The following is a description of a gene set: species: Homo sapiens part of: Lagging Strand Synthesis Reactome Pathway: Processive synthesis on the lagging strand The key event that allows the processive synthesis on the lagging strand, is polymerase switching from pol alpha to pol delta, as on the leading strand. However, the processive synthesis on the lagging strand proceeds very differently. DNA synthesis is discontinuous, and involves the formation of short fragments called the Okazaki fragments. During the synthesis of Okazaki fragments, the RNA primer is folded into a single-stranded flap, which is removed by endonucleases. This is followed by the ligation of adjacent Okazaki fragments., and this is the list of marker genes: POLA1, FEN1, POLD3, POLD2 (NCBI Gene Id 5425), RPA1, DNA2, PRIM2, POLD1, RPA2, RPA3, POLD4, LIG1, POLA2, PCNA, PRIM1